Given this list of marker genes KCNE1, SUMO1, KCNRG, KCNE3, KCNQ1, KCNE2, ANK3, here is a description of the gene set: Any process that stops, prevents or reduces the frequency, rate or extent of delayed rectifier potassium channel activity. Human Gene Set: GOBP_NEGATIVE_REGULATION_OF_DELAYED_RECTIFIER_POTASSIUM_CHANNEL_ACTIVITY species: Homo sapiens